The following is a description of a gene set: Human Gene Set: GOBP_CAVEOLA_ASSEMBLY species: Homo sapiens The aggregation, arrangement and bonding together of a set of components to form a caveola. A caveola is a plasma membrane raft that forms a small pit, depression, or invagination that communicates with the outside of a cell and extends inward, indenting the cytoplasm and the cell membrane., and this is the list of marker genes: PACSIN2, ILK, CAV2 (NCBI Gene Id 858), COL6A1, CAV1, EMP2, IQGAP1, CAV3